The following is a description of a gene set: Mouse Gene Set: GOBP_FATTY_ACID_DERIVATIVE_METABOLIC_PROCESS The chemical reactions and pathways involving fatty acid derivative. studied in species Mus musculus, and this is the list of marker genes: Ehhadh, Elovl7, Dgat1, Cyp4f40, Oxct1, Elovl1, Elovl3, Cyp4f15, Acaa1b, Acot2, Oxct2b, Pecr, Them5, Elovl4, Far2, Hmgcs2, Abhd16a, Pam, Cyp4f13, Fitm2, Far1, Acsl1, Dpep2, Abcd2, Scp2, Fads1, Acot7, Oxct2a, Alox8, Ptgr1, Acox1, Tyrp1, Elovl2, Nudt19 (nudix hydrolase 19), Slc27a5, Alox15 (NCBI Gene Id 11687), Hmgcll1, Elovl6, Elovl5, Dgat2, Acaa1a, Acsl6, Lypla2, Acot8, Aldh3a2, Tmem135, Cyp4f14, Nudt8 (nudix hydrolase 8), Cyp4f18, Nudt7, Hmgcl, Dpep1, Abcd1, Acat1, Hpgd, Awat2, Alox5 (arachidonate 5-lipoxygenase), Alox12, Acsl3, Fads2, Hsd17b4, Gcdh (glutaryl-Coenzyme A dehydrogenase), Ggt5, Acsl4, Acsl5